Given this list of marker genes BAD, BAK1, CASP3, TNFSF10, RARB, GLRX, MCM3, TNFRSF10B, GSN, FAS, CCNE1, TXN, H2BC26, CASP9, TXNIP, GADD45B, MT1L (NCBI Gene Id 4500), FASLG, TP53 (tumor protein p53), BCL2L11, CASP8, APAF1, DFFA, here is a description of the gene set: The path to the discovery of suberoylanilide hydroxamic acid (SAHA, vorinostat) began over three decades ago with our studies designed to understand why dimethylsulfoxide causes terminal differentiation of the virus-transformed cells, murine erythroleukemia cells. SAHA can cause growth arrest and death of a broad variety of transformed cells both in vitro and in vivo at concentrations that have little or no toxic effects on normal cells. It was discovered that SAHA inhibits the activity of histone deacetylases (HDACs), including all 11 known human class I and class II HDACs. HDACs have many protein targets whose structure and function are altered by acetylation including histones and non-histone proteins component of transcription factors controlling gene expression and proteins that regulate cell proliferation, migration and death. SAHA is in clinical trials and has significant anticancer activity against both hematologic and solid tumors at doses well tolerated by patients. A new drug application has been approved for SAHA (vorinostat) treatment of cutaneous T-cell lymphoma. species: Homo sapiens from publication Marks PA (PMID 17322921) Genes whose transcription is up-regulated by histone deacetylase inhibitors. Human Gene Set: MARKS_HDAC_TARGETS_UP